Given this list of marker genes MAG, CLIP3, EPDR1, PSAP, RTN4R, here is a description of the gene set: species: Homo sapiens Binding to a ganglioside, a ceramide oligosaccharide carrying in addition to other sugar residues, one or more sialic acid residues. Human Gene Set: GOMF_GANGLIOSIDE_BINDING